Given this list of marker genes Gm7899, Gm12532, Gm5148, Gm6069, Gm16508, Gm12565, Ankrd50, Gm9723, Gm7815, Pcdh10, Ccna2, Bbs12, 4930594O21Rik, Gm12583 (predicted gene 12583), Gm23796, 3830422I06Rik, Plk4, 8430422M14Rik, Gm25487, Gm26081, Gm7799, Mir7009, Sclt1, Gm7824, Gm20755, Trpc3, 5930409G06Rik, Atp11b, Mccc1 (NCBI Gene Id 97117), Hspa4l, Gm12376, Gm9845, Abhd18, Pabpc4l, B230207O21Rik, Gm18843, Gm25796, D3Ertd751e, Dcun1d1, Gm31266 (NCBI Gene Id 118568628), Spry1, Intu, Il2, Gm23337, Acad9 (acyl-Coenzyme A dehydrogenase family, member 9), Gm15952, Gm12584, 1700052H01Rik, Zfp267, Fat4, Anxa5, Gm11550, C230034O21Rik, Gm12540, Cetn4, Gm32340, Rps23-ps1, Jade1, Gm17835, 5430434I15Rik, Rpl21-ps10, Mccc1os, 6430590A07Rik, Nudt6, 1810062G17Rik, Exosc9, Gm6639, Larp1b (NCBI Gene Id 99525), Gm57858, Gm42921, Gm40038, Mfsd8, 1700027H10Rik, Adad1, 2610316D01Rik, Fgf2os, Gm43308, Fundc2b, Gm22043, Il21, Afg2a, Fgf2, Gm2136 (NCBI Gene Id 329632), Gm32175, Gm10731, Gm7741, Pgrmc2, Gm12582, Bbs7, 1700017G19Rik, Gm17887, Pou5f1-rs11, Gm29739, Gm2011, Slc25a31 (solute carrier family 25 (mitochondrial carrier; adenine nucleotide translocator), member 31), Smim43, Bltp1, Platr4, Gm42922, Gm2965, Gm42437, Qrfpr, Rpl31-ps15, Gm26404, Gm18865, Gm11548 (predicted gene 11548), Gm36823, here is a description of the gene set: studied in species Mus musculus Mouse Gene Set: chr3B